Given this list of marker genes IRF3, IFIH1, TKFC, USP17L2, C1QBP, DHX58, IRF7, RIOK3, ANKRD17, OAS3, DDX60, here is a description of the gene set: Human Gene Set: GOBP_MDA_5_SIGNALING_PATHWAY The series of molecular signals initiated by the binding of dsRNA from another organism to the cytoplasmic pattern recognition receptor (PRR) MDA-5 (also known as IFIH1). MDA-5 detects RNA synthesized during viral replication or shed by non-viral pathogens, and triggers a signaling pathway to protect the host against infection, for example by inducing the expression of cytokines. species: Homo sapiens